The following is a description of a gene set: from publication Yevshin I, Sharipov R, Kolmykov S, Kondrakhin Y, Kolpakov F (PMID 30445619) Genes containing one or more binding sites for (Stfa1) in their promoter regions (TSS -1000,+100 bp) as identified by GTRD version 20.06 ChIP-seq harmonization. Mouse Gene Set: STFA1_TARGET_GENES species: Mus musculus, and this is the list of marker genes: Col22a1, Dedd2, Sigmar1, Oxnad1 (NCBI Gene Id 69703), Rpa1, Pld3, Coq9, Mrpl47, Ldhb, Ccnl1, Grwd1, Ppib, Med7, Etfa, Mir1956, Ktn1, Tmie, Kxd1, Src, Dhcr7, Gm10190, Thsd7a, Smox, Edrf1, Rnf213, Itsn1, Ugt1a6b, Prex1, Atpaf1, 4933400C23Rik, Mknk2, Snx3, Asf1b, Bard1, Ndufa10, Pspc1, Manf, Cfl2, Rnu7, Zfp617, Gm15958, Dgcr8, Zfp280b, Clec2d, Gm24468, Evi5, Anapc4, Pex11b, Mpc1, Rgs11, Mrpl12, Aldoa, Cyp2u1, St6gal1, Fxyd1, Cmpk1, A730049H05Rik, Psmc3ip, Gadd45gip1, Faxdc2, Gpcpd1, Klhdc7a, 1600014C23Rik, Ei24, Rexo1, Khdrbs3, Anpep, AA986860, Arhgap22, Slc29a1, Git1, Tpcn2, A630014C17Rik, Tspan18, 1700096J18Rik, Rnase13, Ftsj1, Bicdl1, Ccdc57, Dph3, 4933440N22Rik, Nr2f6, Slc31a2, Letmd1, Nupr1, Mllt11, Epg5, Cox20, Cacng3, H13, Dnaaf2, Calu, Blm, Gm11638, Ghr, Gm13807, Fam120a, Znrd2, Ik, Star, Mrpl39, Ptms, Pou2af3, 9330198N18Rik, Alkbh7, Zfand5, 1810064F22Rik, Aifm3, Gcnt7, Spaar, Mta2, Ankib1, 5830462I19Rik, Rhobtb1, Vps33a, Afg3l1, Sh3d21, Idh1, Plaat1, Hdac5, Bace2, Ephx1, Pdzd7, Esrra, Ilrun, Mir9-2hg, Gm25127, Ciapin1, Suds3, 1700034J04Rik, Tcf4, Sorbs3, 4930527J03Rik, Inpp4a, Snord59a, Zfp385c, Rras2, Morc3, Dnajc11, 1700020A23Rik, Smarcb1, Stard5, Alkbh3os1, Rapgef1, Ywhag, Mrap (melanocortin 2 receptor accessory protein), Tns1, Tmem160, Rfc4, Psmb3, Tmem37, Trp53inp2, A530064N14Rik, Macf1, Efcc1, Zcwpw2, Bcl3, Gm5532, Magi3, Med28, Kri1, Dnaaf9, n-R5s88, Kmt5b, A930018P22Rik, Dhx32, Nr0b2, Eif4e, Elovl5 (NCBI Gene Id 68801), Zfr2, Klk1b24, Spata2l, Zfp526, Nedd4, Zfp710, Atp5pf, B230369F24Rik, Gm15779, Gm22353, Sgk1, Gm25091, Epn2, Tyrp1, 2210406O10Rik, Ctnna3, Mir1929, Tcea2, Lysmd2, Als2cl, Akap1, Fam81a, Itgb3bp, Mir935, Anxa3, Rab4b, Hspa8, Atp5mg, Crat, Galt, Cryge, 4930524O07Rik, Tinagl1, Gm23530, Nfkbid, Gm16380, A430102K17Rik, Gsta3, Prdm11, Mir2139, Abhd3, Igfbp2, Ppcs, Smim12, Timp3, Tbc1d32, Naca, Tfrc, 4930520O04Rik, Sdhd, Amacr, 5330439K02Rik, Atf4, Fam162a, Cdk4, 2200002J24Rik, Mbnl1, Slc25a10, Sgk3, Fkbp8, Sec14l4, Ndufs7, Micos10, Prmt8, Gm22827, Krit1, Psmd13, Gm14866, Neat1 (NCBI Gene Id 66961), Ankrd24, Qrsl1, A730081D07Rik, C1qtnf3, Mapk1, Smim8, 5031425E22Rik, Tnfaip2, Sf3a2, Grep1, Pex2, Kif1b, Atp5f1b, Ogt, Ccnl2, Triobp, Mtnap1, Mir199a-1, Aptx, Fam78a, Saxo1, Pafah2, Tmem222, Cfap126, Gm33366, Cyp24a1, Gm24536, A230107N01Rik, Gm15895, Cyth1, Otulin, Fkbp5, Gm10829, Gm6822, Zmat5, Tomm40l, Larp1, Phf5a, Nadsyn1, Cdv3, Rdh13 (NCBI Gene Id 71482), Nenf, Slc35c2, Gm12925, Rpl21, Me3, Slc10a5, Ube3a, Gckr, Clcf1, Uck1, Ube2j2, Abca1, Gm15541, Grcc10, Sergef, Ptpa, Slc19a1, Tle5, Smad3 (NCBI Gene Id 17127), Prr7, Itgax, Mkrn1 (NCBI Gene Id 54484), Eif4a1, Junos, Cdk15, Slc4a3, Gm14280, Rnf182, St6galnac6, Comtd1, D130020L05Rik, H6pd (NCBI Gene Id 14379), Narf, Car2, Rmnd5a, Caprin1, Camsap1, A130050O07Rik, Slc45a4, Ogdh, Sema4b, Cyp4f14, Bhmt, Vps13c (NCBI Gene Id 97581), Commd5, Ndufb6, Pgk1, Slc36a4, Dgkd, Ccne1, Akr1b10, Thra, Igsf9, 2300009A05Rik, Mir9-2, Lin7b, Sord, Lpcat3, Mapk9, Pomp, Ppp2r5b, Zmynd12, 2310039H08Rik, Plekhj1, Rcbtb1, Faah, Gemin4, Slf2, Tmem161b, Zbtb12 (zinc finger and BTB domain containing 12), Eci2, Fggy, Stxbp3, Serpinb1a, Zfp933, Gpx4, Gapdh, Gba1, Xylb, Cox8a, Nfe2l1, Dnmt3a, Tia1, Gm25767, Pi4kb, 4930563E18Rik, Rnf44, Dhcr24, A830008E24Rik, Nadk, Uqcr10, Nf1, Atp2a2, C030037D09Rik, Mir3074-2, Shoc2, Fxr1, Capns1, Cyp2f2, Plekha7, Prep, Dbil5, Gm20605, Slc27a5, Mfsd10, Akap10, Snx14, Dtd2, Sh2b1, Gabpa, Mt1, Fbxo21, U2surp, Coro1c, Mycbp, Defb45, Wsb2, Fam234b, Kmt2e, Gm26524, Gm14486 (predicted gene 14486), Rbm25, Gm10244, Gm28513, Timm8b, Dnm3, Septin6, Pgap6, F730043M19Rik, Timm10, Msi2, Zfp266, Hif1an, Rpa2, Plec, Rsad1, Gm27021, Emc8, Ctdspl, Hspa1l (NCBI Gene Id 15482), Fastk, 2210417A02Rik, Atp10d, Chd8, Fkbp2, Rtn4ip1, Pfn4, 2410006H16Rik, Ciao3, Slc25a39, Gm16638, Oat, Rasgrp2 (RAS, guanyl releasing protein 2), Slc5a6, Furin, Abr, F630040K05Rik, Il12a, Eif4h, Irag2, Lgmn, Swi5, Lrrk2, A430057M04Rik, Gm6133, Hectd2os, Tsc22d4, Gm30023 (NCBI Gene Id 118568641), Folr1, Gm16759, Nfib, Pomt1, Gm14221, B3galnt2, 1700001G11Rik (NCBI Gene Id 69303), Gtf2i, Arhgap23, Pcolce, Efcab2, Gm15651, Ppia, Aspscr1, Mrtfa, Tor1aip1, Gm5420, Capzb, 3300002A11Rik, Rnasel, Pptc7, Matcap2, Nploc4, Cerk, Duxf1, Zfp184, Acbd5 (NCBI Gene Id 74159), Macroh2a1, Gm23202, 4930592C13Rik, Htr4, Gm26165, Tpm3, Traip, Got1, Alpl, C3 (complement component 3), Zfp768 (zinc finger protein 768), Bptf, Klf16, BC025920, Mef2c, Cbfa2t2, Spag9, Psme1, Serpina5, Arid1b, Fndc7, As3mt, Map4, Dhps, Gm16740, Tango2, Ndrg2, Snx29, Pimreg, Fam193a, Acacb, Gm14285, Cfap157, Ndufb5, Trmt1, Ncor2, Vim, Ppp1r12b, Car8, Hspa9, Lrch4, Camk2d, Aco2, St6galnac4, Pcyt2, Pak1ip1, Gm38901, Sirt2, Zfp961, Emc4, Fam131c, A430078I02Rik, Nr1d1 (NCBI Gene Id 97769), Whamm, Hspa1a, Gm9910, Sag, Hectd1, Khk, Wnt5b, Casp16, Tmem50a, Gm16573, Klk1b8, Nqo2, Ppp1cc, Frmd8os, Cemip, Mtrf1l, Tnnt1, Islr2, Luc7l, Gm9934, Rnf10, Atp5mc3, Mob1b, Gm20109